Given this list of marker genes Rab18, Ear6, Epx, Eef2, Pkm, Impdh2, Cant1, Kcnab2, Ampd3, Defa17, H2-M9, Tubb4b, Rab3a, Copb1, Tarm1, Defa23, Cct2, Olfm4, Eef1a1, Bri3, H2-M3, Gsn, Csnk2b, C3, Rab6a, Clec4b1, Nfasc, Capn1, Hvcn1, Jup, Clec4n, Armc8, Sting1, Nfam1, Tnfrsf1b, Dynll1, Naprt, Hk3, Pgm2, Slco4c1, Elane, Vat1, Frmpd3, Serpinb3b, Slc2a5, Ear2, Ms4a3, Prdx4, C5ar1, Psmd6, Arpc5, Sh3glb2, Fabp5, Rab5c, Slc44a2, Defa42, Slc27a2, Defa26, Crisp2, Actr2, Prss3, Ptprc, Tspan14, Erp44, Defa3, Ear10, Svip, Adgre5, Camp (cathelicidin antimicrobial peptide, NCBI Gene Id 12796), Mif, Defa32 (NCBI Gene Id 100041890), Psmd1, Pa2g4, Pfkl, Adam8, Gstp1, Ptpn6, Prss2, Atg7, Qpct, Cr1l, Galns, Cyba, Tmem30a, Prcp, Arhgap45, Cdk13, Aldoa, Acaa1b, Prg2 (proteoglycan 2, bone marrow), Itgb2, 2310033P09Rik, Cpped1, Psg22, Gpr84, Mvp, Pdap1, Clec4a3, Cracr2a, Lamtor2, Defa37, Defa31, Creg1, Defa30, Prg3, Nme2, Defa41, Lamp2, Fcna, Bpi, Neu1, Cxcl1, Nhlrc3, Itgax, Anxa2, Clec4b2, Defa21, Psmd7, Apeh, Dsg1a, Kpnb1, Atp6v0c, Crispld2, Anpep, Cfp, Tmem63a, C3ar1, Orm1, Rap2c, Psmb7, Cd36, Clec12a, Pnp, Cstb, Defa36, Rab10, Fcnb, Hbb-bt, Cst3, Ghdc, Arhgap9 (Rho GTPase activating protein 9), Orm2, Cct8, Psmd13, Stk10, Lta4h, Dock2, Fth1, Defa35, Ifi205, Defa43, Clec4a2, Folr2, Serpinb3c, Cmtm6, Atp8a1, Atp6v1d, Clec4a4 (C-type lectin domain family 4, member a4), Mcemp1, Defa25, Ppia, Defa34, Xrcc6, Defa20, Igf2r, Fpr1, Ifi211, Mospd2, Arg1, Cotl1, Enpp4, Hebp2, Fgr, Atp11b, Defa24, H2-M10.6 (NCBI Gene Id 399549), Vamp8, Cfd, Ist1, Hmox2, Cep290, Atp6ap2, Atp6v0a1, Grn, Ddost, Oscar, Lilra5, Ahsg, Defa38, Ifi204, Kcmf1, Defa39, Tcirg1, Cd68, Chit1, Cd177, Nfkb1, Rnase2b, Defa28, Psg29, Mmp25, Aldh3b1, Arl8a, Tlr2, Mmp8, Vps35l, Itgal, Mapk14, Cd55, Rab37, Rnase2a, Cystm1, Faf2, H2-M2, Hmgb1, Rab44, Cd14, Pycard, Man2b1, Snap29, Rab9b, Ticam2, Plaur, Clec4d, Vcp, Gsdmd, Ap1m1, Siglecf, Irag2, Arsa, Npc2, Alad, Pglyrp1, Cap1, Psmc3, H2-M10.2, Dynlt1b, Psmc2, Fgl2, Siglece, Ckap4, Glipr1, Psma2, Lamtor1, Psap, Dnase1l1, Serpinb3a, Unc13d, Psma5, Cda, Ctsd, Ormdl3, Hexb, Try10, Plau, Ilf2, Tyrobp, Gdi2, Ctss, H2-Q10, Adgrg3, Ptges2 (NCBI Gene Id 96979), Slpi, Pnp2, Cxcr2, Dok3, Ear1, B2m, Rab7, Cnn2, Ceacam2, Cxcr1, H2-Q7, Ctsc, Psmd12, Psen1, Ctsh, Actr10, Prtn3, Rnaset2a, Slc11a1, Tnfaip6, Pigr, Ceacam1, Vnn1, Vapa, Ctsg (cathepsin G), 1600012H06Rik, Hp, Sdcbp, H2-M10.1, Tom1 (NCBI Gene Id 21968), Dynlt1a, here is a description of the gene set: Reactome Pathway: Neutrophil degranulation This event has been computationally inferred from an event that has been demonstrated in another species.<p>The inference is based on the homology mapping from PANTHER. Briefly, reactions for which all involved PhysicalEntities (in input, output and catalyst) have a mapped orthologue/paralogue (for complexes at least 75% of components must have a mapping) are inferred to the other species. electronically inferred by orthology from the curated human pathway studied in species Mus musculus part of: Innate Immune System